The following is a description of a gene set: part of: Mitotic Metaphase and Anaphase species: Homo sapiens The metaphase to anaphase transition during mitosis is triggered by the destruction of mitotic cyclins. Reactome Pathway: Mitotic Metaphase/Anaphase Transition, and this is the list of marker genes: FBXO5, PLK1